The following is a description of a gene set: Human Gene Set: GSE32255_WT_UNSTIM_VS_JMJD2D_KNOCKDOWN_4H_LPS_STIM_DC_UP In dendritic cells, expression of the H3K9me3 demethylase JmjD2d is upregulated by LPS stimulation. To identify genes whose induction by LPS depends on JmjD2d activity, we performed a microarray analysis of wild-type and JmjD2d-knockdown dendritic cells, before and after stimulation with LPS. studied in species Homo sapiens Genes up-regulated in dendritic cells: unstimulated wildtype versus KDM4D knockdown (shRNA) stimulated by LPS. from publication Zhu Y, van Essen D, Saccani S (PMID 22633489), and this is the list of marker genes: SSBP2, ICAM2, SZT2, BANK1, DSE, IGF1R, ZNF394, SH3GL3, SMURF1, RPS9, INTS7, GP1BA, AAK1 (AP2 associated kinase 1), EIF2B4, AGK, PDLIM1, RPL8, SFSWAP, KLHL3, MRPL41, RNF145, SH2B3, TCOF1, CNST, PHF12, MARS2, ITPR1, PAG1, RNF114, CRTAM, THAP11, ECT2L, BCL9L, PJA1, LRRC8A, FOXK1, NUP153, IKBKE, GPSM3, NSG2, TNFSF8, ABTB3, NMNAT2, TMEM71, MED13L, RXRB, NUP210, SESN3, PDCD7, ABCG1, MDC1, SLC11A2, PDE3B, ASTE1, CREBBP, RPL37, USP12, PHF21A, PUS3, EXT1, KLRD1, DCK (deoxycytidine kinase), NOP10, GPM6B, TLE4, ST3GAL1, LTB, MAPDA, YEATS2, REXO1, PVR, RBM38, PRDM2, ATP11B, ECEL1, MAP3K1, HDHD5, SNRK, DTX2, UCK2, ARFGEF2, TAF7, TRAF5 (TNF receptor associated factor 5), IL17RA, RNF19A, FOXO1, OSTF1, ZNRF2, IVD, TUT1, RBCK1, PTPN12, ABHD8, SINHCAF, USP6NL, USP18, UCKL1, PFDN5, TNFRSF1A, PPM1H, MLH3 (mutL homolog 3), PPTC7, CEP68, WFIKKN2, EIF4B, URB1, RNF38, IL1RL2, NF1, RALGPS1 (Ral GEF with PH domain and SH3 binding motif 1), RNF144A, STX17, BTLA, LRRC14, SPNS1, TARBP1, PFKFB3, IL6R, SLC26A11, FHIP2A, SPIN4, LCK, SH3KBP1, GADD45A, KDM3A, JAML, BZW2, FRAT1, SPSB1, COMMD8, ST8SIA1, DGKZ, RANBP10, HSD17B10, NDUFA6, MGAT4A, IMP3, BCL2L11, PRKCQ, MIB2, PLEKHA1, JARID2, CMAHP, TSPAN5, GGCT, PEX5, GYPC, MCUR1, ARID5A, C1GALT1 (core 1 synthase, glycoprotein-N-acetylgalactosamine 3-beta-galactosyltransferase 1), RASGRP2, PCGF5, TTC13, CHN1, FRS2, CRIM1, KTI12, SDHC, TMC6, PGAP1, KLHL25, WNT2B, PDLIM5, HIPK1, RETREG3, ABLIM1 (NCBI Gene Id 3983), ITGA7, IFIT2, FAM222B, TXK, PRRC2C (proline rich coiled-coil 2C), RRAS2, ENTPD5, VPS18, BACH2